The following is a description of a gene set: Systems vaccinology has emerged as an interdisciplinary field that combines systems wide measurements and network and predictive modeling applied to vaccinology. Here we used the systems vaccinology approach to study the molecular mechanisms underlying th from publication Nakaya HI, Wrammert J, Lee EK, Racioppi L, Marie-Kunze S, Haining WN, Means AR, Kasturi SP, Khan N, Li GM, McCausland M, Kanchan V, Kokko KE, Li S, Elbein R, Mehta AK, Aderem A, Subbarao K, Ahmed R, Pulendran B (PMID 21743478) species: Homo sapiens Human Gene Set: GSE29618_PRE_VS_DAY7_POST_LAIV_FLU_VACCINE_MONOCYTE_DN Genes down-regulated in comparison of monocytes from LAIV influenza vaccinee pre-vaccination versus those at day 7 post-vaccination, and this is the list of marker genes: ZNF93, HSPA1A, IFFO1, ARHGAP19, GEMIN4, CBX1, SATB2, NPY5R, CENPE, FIRRM, DHX16, OLFM1, SPATA7 (NCBI Gene Id 55812), CCL4, ZNF468, FAM216A, COCH, EGR1, MBL1P, CPPED1, ELOVL4, CCNL1, OSR2, ENOX2, SLA, PRPSAP1, ATP13A1, RSRP1, NAGA, SORD, NOLC1, ZFAND1, C17orf75, JADE1, AAR2, NOP56, SEZ6L, RPL15, PDE6C, RAB3GAP2, OSBPL8, LPAR1, NAALAD2, KPNA2, KATNA1, BTK, KLHL41, PDLIM5, IL27RA, UNC119B, CMAS, HGFAC, RPL23, APAF1, CIITA, ZNF254, MEIS1, TRDV2, PUS7, ZNF225, NCBP2, BTG2, PREPL, EXOSC5, GPATCH1, ARHGAP10, USE1, RFX2, RXRA, TPD52L1, CAB39, TMCO1, ABHD2, PINK1, TTC9, DOK1, IER2, PTEN, GPR107, SMARCC2, ST6GALNAC2, ASXL1, CDK5R1, SYNE2, DAZAP1 (DAZ associated protein 1), ZFP36L2, ESF1, ZNF226, DPF3, ZNF432, ADNP, LRIG2, MMACHC, UBR4, ZFP64, LYST, YIPF1, KLHL11, CLDN18, SLC25A32, USP33, LAT2 (NCBI Gene Id 7462), SSR3 (signal sequence receptor subunit 3), OGFOD3, IP6K1, CLDN17, BICRAL, SLC25A5, MBP, IER5, FOSB, GPX2, ANG, DPP8, POLR1E, RPL36AL, TADA2A, ZNF106, PAPPA2, ZNF43, RPS27A, ACP6, VRK1, SLC6A20, GPATCH4, SYNPO, CRTAP, GEMIN2, FKBP5, SKAP2, CDC25B, ATP6V1B2, IL6 (interleukin 6), ZFAND5, AFDN, PPP2R5E, MFSD1, MMS19, TRAPPC11, ZNF146, JUN, TAF12, WDR12, TMC5, DUSP1, EIF5, TOPBP1, EPM2A (NCBI Gene Id 7957), RAB7A, CCDC25, TRA2B, NOP14-AS1, TUT7, SECISBP2, TRIM37, EEF2KMT, MYOM2, PPFIBP1, RPGRIP1, TNFAIP1, GMPR2, UBA3, KIF1A, WWP2, RBM25, CLCN1, IPO5, ZBBX, EIF2B4, NEK9 (NCBI Gene Id 91754, NIMA related kinase 9), PSMD14, RCC1L, TTF2, TRAPPC8, BMP3, MCTP1, GGA3, DCAF4, DMXL1, PTGDR, FAM234B, ATXN1, TJAP1, ALDH3A2, TNFRSF10C, RANBP10, SEPTIN8, MPL, ABCA7, PDGFC, APEX1, PFDN4, SRGAP2, GTF3A, THBS2, SMG7-AS1, DNAAF2, PER2, CLCN7, TXLNG